The following is a description of a gene set: Human Gene Set: HP_PROGRESSIVE_DISTAL_MUSCULAR_ATROPHY Progressive distal muscular atrophy Progressive muscular atrophy affecting muscles in the distal portions of the extremities. studied in species Homo sapiens, and this is the list of marker genes: CFAP410, SQSTM1, FUS, VAPB (VAMP associated protein B and C), SOD1, ASAH1, CHCHD10, PNKP, HNRNPA1, UNC13A, PON3, TARDBP, ERBB4, CHMP2B, ANG, TREM2, DCTN1, OPTN, PFN1, MATR3, TRPV4, TBK1, NEFH, PPARGC1A, VCP, PON1, TAF15, GLE1, DAO, CCNF, PON2, ATXN2, GLT8D1, PRPH, UBQLN2, FIG4, ANXA11, NEK1